The following is a description of a gene set: studied in species Mus musculus Any process that activates or increases the frequency, rate or extent of the non-canonical NF-kappaB cascade. Mouse Gene Set: GOBP_POSITIVE_REGULATION_OF_NON_CANONICAL_NF_KAPPAB_SIGNAL_TRANSDUCTION, and this is the list of marker genes: Tlr3, Tlr4, Eda, Nod1, Ago1, Egfr, Map3k7, Rbck1, Terf2ip, Nod2, Vcp, Il18, Tcim, Adissp, Ccl19-ps6, Smpd3, Tnfsf14, Nmi, Phb1, Rc3h2, Hmgb1, App, C1qtnf4, Nlrp12, Trim44, Pdcd4, Trim55, Rc3h1 (NCBI Gene Id 96936), Trim56, Tlr2, Il18r1, Cd86, Ddx3x, Rela, Phb2, Edn1, D1Pas1, Ccl19, Ago3, Edar, Ccl19-ps4, Edaradd, Ripk1, Rps3, Laptm5, Sash1, Nlrp3, Il1b, Trem2 (triggering receptor expressed on myeloid cells 2, NCBI Gene Id 83433), Calr, Sphk1, Pycard, Trim26, Rtkn2 (NCBI Gene Id 631847), Ifi35, Eif2ak2, Grem1, Tnf, Tlr9, Ptp4a3, Havcr2, Lrrc19, Ager, Tlr7, Crebbp, Ank3 (NCBI Gene Id 73013), Ccl19-ps1, Ccl19-ps5, Actn4, Trip6, Ccl19-ps3, Nr3c2